Given this list of marker genes IFIH1, TMEM53, CDH11, HPGD, AP1S2, SMAD4, PDE4D, NONO, ACBD6, GNPTAB, LRP4, PTDSS1, SGMS2, NOTCH3, RUNX2, ERCC8 (ERCC excision repair 8, CSA ubiquitin ligase complex subunit), TNFRSF11B, FLNA, AGA, DVL1, LRP5, MAN2B1, ERCC6, POLR3A, GLB1, SLC17A5, TMEM67, PHF6, PLEKHM1, DYM, PTH1R, AMER1, CA2, ANKH, GNAS, COL11A1, SFRP4, SMS, AXIN1, RPS6KA3, SNX14, here is a description of the gene set: Human Gene Set: HP_THICKENED_CALVARIA The presence of an abnormally thick calvaria. Thickened calvaria studied in species Homo sapiens